Given this list of marker genes SAT1, FOS, PLCB4, MT1E, TMSB4X, MYH9, GRN, MT1H, here is a description of the gene set: species: Homo sapiens from publication Mariadason JM, Corner GA, Augenlicht LH (PMID 10969808) Cluster 1: genes up-regulated in SW260 cells (colon cancer) by sodium butyrate, curcumin, sulindac and TSA. The short-chain fatty acid butyrate, produced by microbial fermentation of dietary fiber in the large intestine, is a physiological regulator of major pathways of colonic epithelial cell maturation: cell cycle arrest, lineage-specific differentiation, and apoptosis. Microarray analysis of 8,063 sequences demonstrated a complex cascade of reprogramming of SW620 colonic epithelial cells upon treatment with butyrate characterized by the progressive recruitment of gene sets as a function of time. Comparison with the effects of trichostatin A, in conjunction with differences in the kinetics of alteration of histone acetylation induced by butyrate and trichostatin A, identified subsets of induced and repressed genes likely coordinately regulated by altered histone acetylation. The butyrate response was also compared in detail with that of sulindac, a nonsteroidal anti-inflammatory drug with significant chemopreventive activity for colon cancer, and curcumin, a component of mustard and curry structurally and functionally related to sulindac that also has chemopreventive activity. Although gene clusters were identified that showed similar responses to butyrate and sulindac, the data were characterized by the extensive differences in the effects of the two agents. This was striking for functional classes of genes involved in signaling pathways and in cell cycle progression, although butyrate and sulindac induce a similar G0-G1 arrest, elevation of beta-catenin-Tcf signaling, and apoptotic cascade. As regards cell cycle arrest, the underlying mechanism in response to butyrate was most similar to that of the Caco-2 cell line that had spontaneously undergone a G0-G1 arrest and least similar to the G2-M arrest stimulated by curcumin. Thus, high-throughput microarray analysis of gene expression profiles can be used to characterize and distinguish the mechanisms of response of colonic epithelial cells to physiological and pharmacological inducers of cell maturation. This has important implications for characterization of chemopreventive agents and recognition of potential toxicity and synergies. The data bases, gene clusters, and analyses are available at http:// sequence.aecom.yu.edu/genome/. Human Gene Set: MARIADASON_RESPONSE_TO_BUTYRATE_CURCUMIN_SULINDAC_TSA_1